Given this list of marker genes HNF1A, BTG1, NACA, PTPN11, BCL7A, here is a description of the gene set: studied in species Homo sapiens from publication Myllykangas S, Himberg J, Böhling T, Nagy B, Hollmén J, Knuutila S (PMID 16751803) DNA copy number amplifications activate oncogenes and are hallmarks of nearly all advanced tumors. Amplified genes represent attractive targets for therapy, diagnostics and prognostics. To investigate DNA amplifications in different neoplasms, we performed a bibliomics survey using 838 published chromosomal comparative genomic hybridization studies and collected amplification data at chromosome band resolution from more than 4500 cases. Amplification profiles were determined for 73 distinct neoplasms. Neoplasms were clustered according to the amplification profiles, and frequently amplified chromosomal loci (amplification hot spots) were identified using computational modeling. To investigate the site specificity and mechanisms of gene amplifications, colocalization of amplification hot spots, cancer genes, fragile sites, virus integration sites and gene size cohorts were tested in a statistical framework. Amplification-based clustering demonstrated that cancers with similar etiology, cell-of-origin or topographical location have a tendency to obtain convergent amplification profiles. The identified amplification hot spots were colocalized with the known fragile sites, cancer genes and virus integration sites, but global statistical significance could not be ascertained. Large genes were significantly overrepresented on the fragile sites and the reported amplification hot spots. These findings indicate that amplifications are selected in the cancer tissue environment according to the qualitative traits and localization of cancer genes. Human Gene Set: MYLLYKANGAS_AMPLIFICATION_HOT_SPOT_30 Amplification hot spot 30: colocolized fragile sites and cancer genes in the 12q21-q24.3 region.